The following is a description of a gene set: Any process that results in a change in state or activity of a cell or an organism (in terms of movement, secretion, enzyme production, gene expression, etc.) as a result of a prostagladin D stimulus. Human Gene Set: GOBP_RESPONSE_TO_PROSTAGLANDIN_D species: Homo sapiens, and this is the list of marker genes: ANKRD13C, PTGDR2, AKR1C3, PTGFR, AKR1C2, PTGDR, TNC